The following is a description of a gene set: Catalysis of the reaction: acetyl-CoA + n malonyl-CoA + 2n NADH + 2n NADPH + 4n H+ = a long-chain acyl-CoA + n CoA + n CO2 + 2n NAD+ + 2n NADP+. Mouse Gene Set: GOMF_FATTY_ACYL_COA_SYNTHASE_ACTIVITY species: Mus musculus, and this is the list of marker genes: Acsm5 (NCBI Gene Id 272428), Acsm2, Slc27a3, Acsm4, Acsm3, Acsm1